The following is a description of a gene set: Mouse Gene Set: MCBRYAN_PUBERTAL_BREAST_4_5WK_DN Expression microarray analysis identified over genes regulated during puberty in the mouse mammary gland. Most prominent were genes whose expression increased in parallel with pubertal development and remained high thereafter. Members of the Wnt, transforming growth factor-beta and oestrogen-signalling pathways were significantly overrepresented. Comparison to expression data from CITED1 knockout mice identified a subset of oestrogen-responsive genes displaying altered expression in the absence of CITED1. Included in this subset are stanniocalcin2 (Stc2) and amphiregulin (Areg). Chromatin immunoprecipitation revealed that ERalpha binds to oestrogen response elements in both the Stc2 and Areg genes in the mammary gland during puberty. Additionally, CITED1 and ERalpha localize to the same epithelial cells of the pubertal mammary gland, supporting a role for interaction of these two proteins during normal development. In a human breast cancer data set, expression of Stc2, Areg and CITED1 parallel that of ERalpha. Similar to ERalpha, CITED1 expression correlates with good outcome in breast cancer, implying that potential maintenance of the ERalpha-CITED1 co-regulated signalling pathway in breast tumours can indicate good prognosis. Genes down-regulated during pubertal mammary gland development between week 4 and 5. species: Mus musculus from publication McBryan J, Howlin J, Kenny PA, Shioda T, Martin F (PMID 17486082), and this is the list of marker genes: Ahcyl1, Igfals, Lasp1, Rbbp4, Cox7a1, Plin5, Ogt, Cox8b, Tpsb2, Ehd2, Fhl1, Epb41l2, Zfand5, Eif4g1, Prxl2b, Gid4, Rcc1l, Prkce, Retnla, Fmc1, Coq8a, Lpl, Jag1, Slc16a2, Reep6, Atpaf2, Pfkfb3, Hccs, Kif1c, Lama4, Bltp3a, H2-Aa, Rps6ka3, Cdh5, Trac, Art3, Norad, Nr1d1, Sorbs1, Cp, Gpd1, Slc25a10, Gpam, Mpz, Ednra, Ccn1, Pdcd6ip, Ets1, Car13, Ehhadh, Mtarc1 (NCBI Gene Id 66112), Slc2a4, Nid2, Bche, Tmem14c, Ltc4s, Prkacb, Extl3, Rnase2a, Ppp6r3, Mbtps1, Cisd1, P2rx5, Neat1, Fabp4, Tspan17, H3c15, Fabp3-ps1, Acad9, Pdk4, Nrk, Cd8a, Seh1l, Nipsnap3b, Letmd1, Dnm2, Pcmtd1, Rab5b, Nnat, Csnk2a1, Etfdh, Suclg1, Per3, Mtch2, Gk, Ddx6, Ppa1, Cux1, Scd2, Hspg2, Acsl1, Qki, Acadvl, Dlat, Lgals12, Cyth1, Zfp91, Epas1, Golph3, Ube4a, Gm2a, Bcat2, Aatk, Rassf3, Acat1, Pdk1, Ehd1, Ndn, Mapk8ip1, Gys1, Sod2, Paqr4, Ppp1r3c, Malat1, Chrdl1, Kcnb1, Wfdc21, Fabp5, Atp6v0a1, Anxa8, Pex6, Aldh1l1, Acaa2, Steap3, Sfxn1, Ucp1, Dmac2, Slc25a35, Sh2b2 (NCBI Gene Id 54699), Myo1c, Galnt2, Atp5f1d, Cspg4, Ube3a, Ptges2, Acvr1c, Kdm5c, Adissp, Bpnt1, Mcrip2, Zfp106, Apoc2, Grb10, Ywhag (NCBI Gene Id 52802), Eral1, Acly, Lipa, Mlxipl, Adrb3, St6galnac5, Ppp1r8, Klhl2, Tbl1xr1, Immt, Tpp2, Mlx, Prelp, Stom, Akt2, Bmp1, Tie1, Ptpn14, Coq5, Kcnk3, Tmem45b, Fscn1, Igfbp4, Acaca, Acsf2, Sh2b3, Idh3b, Blcap, Ccnk, Nfic, Tns1, Akt1, Cpt1b, Nid1, Aplp2, Ech1, Pycr1, Aco2, Slc7a10, Klf15, Tfrc, Notch4, Scd3, Dbt, Cidea, Zbtb16, Dmpk, Eci1, Kcnk2, Ykt6, Hipk2, Lrp5, Ppargc1b, Tmem109, Sod3, Carhsp1, Wee1, Cavin1, Vegfa